The following is a description of a gene set: species: Homo sapiens An abnormal reduction in the amount of pigmentation (reduced or absent) of the iris and retina. Human Gene Set: HP_OCULAR_ALBINISM Ocular albinism, and this is the list of marker genes: SLC45A2, SKI, HPS6 (NCBI Gene Id 95477), TYR (tyrosinase), HPS4, KCNAB2, GPR143, RERE, UBE4B, HSPG2, LUZP1, EPG5, HPS5, DTNBP1, HPS1, BLOC1S3, PRKCZ, GABRD, SOX10, CASZ1, SPEN, BLOC1S5, PRDM16 (NCBI Gene Id 647868), PDPN, MMP23B, AP3B1, AP3D1, BLOC1S6, LYST